The following is a description of a gene set: studied in species Homo sapiens A plasma membrane region adjacent to the base of eukaryotic cilia and flagella that is enriched in endocytosis-associated proteins and vesicles and that appears to regulate ciliary membrane homeostasis. Human Gene Set: GOCC_PERICILIARY_MEMBRANE_COMPARTMENT, and this is the list of marker genes: KIFAP3, RP2, ADGRV1, USH2A, WHRN, KIF17